The following is a description of a gene set: studied in species Mus musculus Glycosphingolipid metabolism Mouse Gene Set: REACTOME_GLYCOSPHINGOLIPID_METABOLISM, and this is the list of marker genes: Glb1, A4galt, Neu4, Glb1l, Hexa, Gba1, Arsj, St3gal5, Sumf2, Arsk, St6galnac5, St6galnac6 (ST6 (alpha-N-acetyl-neuraminyl-2,3-beta-galactosyl-1,3)-N-acetylgalactosaminide alpha-2,6-sialyltransferase 6), M6pr, Arsi (NCBI Gene Id 545260), B3galt4 (NCBI Gene Id 54218), Ctsa, Cerk, Smpd1, Arsa, Smpd3 (sphingomyelin phosphodiesterase 3, neutral), Neu2, B3gnt5, Galc, Asah2, Neu1, Hexb, Gal3st1, Glb1l3, B4galt6, Fut2, Enpp7, Sumf1, Sts, Fut1, St3gal3, B3galnt1, Neu3, B4galt5, Arsg, Glb1l2, Psap, Asah1 (N-acylsphingosine amidohydrolase 1), Smpd2, Gba2, Smpd4, B4galnt1, St8sia5, Ugcg, Gm2a, Ugt8a, St3gal2, Arsb, Gla